The following is a description of a gene set: species: Mus musculus Mouse Gene Set: VERNOCHET_ADIPOGENESIS from publication Vernochet C, Peres SB, Davis KE, McDonald ME, Qiang L, Wang H, Scherer PE, Farmer SR (PMID 19564408) Genes up-regulated during adipogenic differentiation of 3T3-L1 cells (preadipocyte) and down-regulated by troglitazone. White adipose tissue (WAT) stores energy in the form of triglycerides, whereas brown tissue (BAT) expends energy, primarily by oxidizing lipids. WAT also secretes many cytokines and acute-phase proteins that contribute to insulin resistance in obese subjects. In this study, we have investigated the mechanisms by which activation of peroxisome proliferator-activated receptor gamma (PPARgamma) with synthetic agonists induces a brown phenotype in white adipocytes in vivo and in vitro. We demonstrate that this phenotypic conversion is characterized by repression of a set of white fat genes (visceral white), including the resistin, angiotensinogen, and chemerin genes, in addition to induction of brown-specific genes, such as Ucp-1. Importantly, the level of expression of the visceral white genes is high in mesenteric and gonadal WAT depots but low in the subcutaneous WAT depot and in BAT. Mutation of critical amino acids within helix 7 of the ligand-binding domain of PPARgamma prevents inhibition of visceral white gene expression by the synthetic agonists and therefore shows a direct role for PPARgamma in the repression process. Inhibition of the white adipocyte genes also depends on the expression of C/EBPalpha and the corepressors, carboxy-terminal binding proteins 1 and 2 (CtBP1/2). The data further show that repression of resistin and angiotensinogen expression involves recruitment of CtBP1/2, directed by C/EBPalpha, to the minimal promoter of the corresponding genes in response to the PPARgamma ligand. Developing strategies to enhance the brown phenotype in white adipocytes while reducing secretion of stress-related cytokines from visceral WAT is a means to combat obesity-associated disorders., and this is the list of marker genes: Pank3, Adcyap1r1, Lum, Retn, Pparg, Rarres2, Cebpa (NCBI Gene Id 12606), Fabp4, Sult1a1, Sort1, Aoc3, Adrb3, Hp, Cyp2f2, Ffar2, Mc2r, Apcdd1, Agt, Vnn3